The following is a description of a gene set: Mouse Gene Set: GOCC_ZYMOGEN_GRANULE A membrane-bounded, cytoplasmic secretory granule found in enzyme-secreting cells and visible by light microscopy. Contain zymogen, an inactive enzyme precursor, often of a digestive enzyme. studied in species Mus musculus, and this is the list of marker genes: Ogt, Scamp1, Pnliprp2, Clca1, Vamp2, Dnase1, Rab3d, Gp2, Sycn, Hspd1, Zg16, Anxa4, Dmbt1, Rab27b, Pla2g4a, Slc30a2, Cuzd1, Vamp8, Reg1, Tmed10, Srgn, Gnai3, Kcnq1, Stxbp2, Cel (NCBI Gene Id 78484), Tmed2, Stx3, Slc9a4, Rab5a, Reg3b